The following is a description of a gene set: species: Mus musculus Any process that modulates the frequency, rate or extent of adenylate cyclase activity. Mouse Gene Set: GOBP_REGULATION_OF_ADENYLATE_CYCLASE_ACTIVITY, and this is the list of marker genes: Adcy1, Calca, Adcy4, Drd2, Orai1, Adcy2, Lhcgr, Calcr (calcitonin receptor), Adcy3 (NCBI Gene Id 11509), Palm, Adgrv1, Cacna1d, Akap5, Adcy7, Gng7, Drd1 (dopamine receptor D1), Adcyap1, Stim1, Raf1, Nf1, Cacna1c, Acr, Gnal